Given this list of marker genes Gng5, Gng10 (guanine nucleotide binding protein (G protein), gamma 10), Gngt2, Gng8, Gnb3, Gnb5, Gng7, Gnb2, Gng3, Gng4, Gng11, Cdc42, Gngt1 (guanine nucleotide binding protein (G protein), gamma transducing activity polypeptide 1), here is a description of the gene set: electronically inferred by orthology from the curated human pathway part of: G-protein beta:gamma signalling Reactome Pathway: G beta:gamma signalling through CDC42 studied in species Mus musculus This event has been computationally inferred from an event that has been demonstrated in another species.<p>The inference is based on the homology mapping from PANTHER. Briefly, reactions for which all involved PhysicalEntities (in input, output and catalyst) have a mapped orthologue/paralogue (for complexes at least 75% of components must have a mapping) are inferred to the other species.